The following is a description of a gene set: STING mediated induction of host immune responses Human Gene Set: REACTOME_STING_MEDIATED_INDUCTION_OF_HOST_IMMUNE_RESPONSES species: Homo sapiens, and this is the list of marker genes: STAT6, TRIM21, CGAS, PRKDC, NLRC3, NLRP4, IRF3, DTX4 (deltex E3 ubiquitin ligase 4), XRCC6, MRE11, TBK1, XRCC5, DDX41, IFI16, STING1, TREX1